The following is a description of a gene set: Genes down-regulated in comparison of naive CD8 T cells versus unstimulated NK cells. species: Homo sapiens Immune cell-specific expression is one indication of the importance of a gene's role in the immune response. In order to identify such patterns, we set out to broadly profile gene expression in a variety of immune cells. Human Gene Set: GSE22886_NAIVE_CD8_TCELL_VS_NKCELL_DN from publication Abbas AR, Baldwin D, Ma Y, Ouyang W, Gurney A, Martin F, Fong S, van Lookeren Campagne M, Godowski P, Williams PM, Chan AC, Clark HF (PMID 15789058), and this is the list of marker genes: S1PR5, HIPK2, MAST2, NCKAP1L, LYST, CTBP2 (C-terminal binding protein 2), HIPK1, TACC1, APOBEC3G (NCBI Gene Id 80065), KIR3DS1, CTNNA1, SYK, ARHGEF12, UBE2W, SUSD6, APMAP, LAT2, C5orf15, G6PD, ZNF493, TCF4, PPP1R13L, DHX8, PSME4, RAB11FIP1, TNPO1, SMAD5, ZNF432, TRIP12, MTG1, SLC31A1, NCOA2, PISD, HSD17B3, NFAT5, KIFAP3, AUTS2, TMEM87A, ADCYAP1R1, ITCH, SRGN, NCR1, SNRNP35, ARIH1, RFTN1, LYN, TOX, PPP1R3D, HEG1, LASP1 (NCBI Gene Id 3927, LIM and SH3 protein 1), CHST2, RHOQ, ADAM8, HBQ1, GOLGA2, SLFN12, BAZ2B, CEP43 (NCBI Gene Id 11116), STX4, CSRNP2, LRRC17, NOTCH2, PON2, PHIP, DHCR24, MCF2L2, SASH3, NKAIN1, IST1, LCN2, MTMR3, PPM1B, LPIN1, GOLGA8H, ABHD2, SETX, TNFRSF1A, B2M, EOLA2, TM6SF1, ADAMTS20, YES1, MFSD6 (major facilitator superfamily domain containing 6), TRIM58, ATP10D, RAD23B, CREB3L2, MON2, TIPRL, KIR2DL4, TAOK1, GSN, ELF4 (E74 like ETS transcription factor 4), PCDHGA8, STOM, AKR1C3, LAMP1, PRR14, IL2RB, CERS4, CEBPD, C2CD3, ALPK1, ARID3A, TYROBP, BCL2L2, NARF, FURIN (NCBI Gene Id 5123), ARSJ, ARID5A, MCTP2, MIA2, EXOSC1, RHBDF2, NOTCH1, AP2B1, TBC1D31, PREP, AOAH, SEC24C, BIRC2, PPM1A, STBD1, SART3, ASL, CHST12, NCAM1, JARID2, SELENOT (selenoprotein T), INPP1, PLEKHO2, PLCG2 (phospholipase C gamma 2), YPEL1, VIPAS39, DNM1L, MAML1, ATP8B4, IL18RAP, STX7, FCER1G, EFEMP2, EML2, NME8, TAF15, TARDBP, ACTR8, GFOD1, NPC1, HNRNPK, GZMB, UBB, LTF, PRR5L, CD63, CAMK1D, KMT5B, PPP1R12A, IGF2R, PHC3, ENPP4, ALOX5AP, CD247, ZCCHC24, MED20, WDR45, SLCO4C1, ARAP2, SSH1, INSIG1, RNF4 (ring finger protein 4), PRDM10, RAB14, RNF13, DVL3, TUT7, CFLAR, CRIM1, NLRX1, DAB2 (DAB adaptor protein 2), GALNT3, IL18R1, PTPRC, RTF1, IFI16, TBL1X, SNAP29, RSF1, PHF21A, PPP4C, ZFYVE16, RHOBTB3, ATP2B4, GSE1, PTPRE, GMEB1, S100A9, ZWILCH